The following is a description of a gene set: Pathway Definition from KEGG: SopE -> RAC1 -> (WASF+ABI1+HSPC300+CYFIP+NCKAP1) -> ARP2/3 -> (ACTB,ACTG1) studied in species Homo sapiens Human Gene Set: KEGG_MEDICUS_PATHOGEN_SALMONELLA_SOPE_TO_RAC_SIGNALING_PATHWAY Salmonella SopE to RAC signaling pathway. Pathway ID: N01128. Pathway type: Pathogen. Pathway class: nt06135 Cytoskeletal regulation (viruses and bacteria)., and this is the list of marker genes: CYFIP2, WASF1, ARPC1A, ARPC4, ACTR3, ACTG1, ARPC3, ARPC5, WASF3, ACTR2, ARPC5L, BRK1, ARPC2, ABI1, WASF2, NCKAP1 (NCBI Gene Id 9864), ACTB (actin beta), CYFIP1, RAC1, ARPC1B